The following is a description of a gene set: Human Gene Set: GOBP_SECRETORY_GRANULE_LOCALIZATION Any process in which a secretory granule is transported to, and/or maintained in, a specific location within the cell. studied in species Homo sapiens, and this is the list of marker genes: TRIM46, PIK3CG, KIF1B, BAIAP3, KIF1A, RAB3A, TANC2, UNC13B, PPFIA2, STXBP3, SYT4, UNC13C, KIF5A, MAP2, RASGRP1 (RAS guanyl releasing protein 1), SNAP25, SYBU, CADPS, KIF1C, CADPS2, KIF5B, STXBP2, USO1, UNC13A, STXBP1